The following is a description of a gene set: Human Gene Set: GOMF_TRANSFERASE_ACTIVITY_TRANSFERRING_ONE_CARBON_GROUPS studied in species Homo sapiens Catalysis of the transfer of a one-carbon group from one compound (donor) to another (acceptor)., and this is the list of marker genes: TMT1A, KMT5C, FDXACB1, FAM86B1, RRP8, METTL23, KMT2C, TRMT10C, METTL2B, PRDM6, KMT5A, NOP2, TRDMT1, METTL16, PEMT, EEF2KMT, TRMT11, TRMT13, THUMPD3, SUV39H1, PRDM1 (NCBI Gene Id 639), FTCD, PRDM12, FAM98B, MRM1, CAD, TRMT2B, EMG1, ASMTL, TRMT2A, TRMT61A, FBXO11, GNMT, PRDM8, TRMT5, ATPSCKMT, WDR5, NSUN6, COMT, TTLL12, PCMTD1, EZH2, NTMT1, NNMT, PRDM4, ATIC, VCPKMT, PRDM14, METTL2A, ETFBKMT, BHMT, METTL9, KMT2E, EEF1AKMT1, FAM86B2, HNMT, SETMAR (NCBI Gene Id 6419), SETD6, MRM2, SETDB1, HENMT1, PRMT8, TRMT10A, DOT1L, SMYD4, THUMPD2, SMYD1, GART, METTL3, METTL25B, NSUN4, PRDM11, PRMT2, TRMO, EEF1AKMT2, MRM3 (NCBI Gene Id 55178), CMTR1, CARM1, FAM86C1P, MTFMT, TRMT61B, METTL22, METTL15P1, SPOUT1, NSUN5P2, DNMT3A, DIMT1, NDUFAF5, METTL6, LCMT2, GAMT, AS3MT, MTR (NCBI Gene Id 4548), SIRT7, METTL1, SETD2, SETD1A, SMYD3, SETDB2, METTL13, TRMT1L, SETD9, SETD3, AMT, EZH1, METTL21EP, GATM, OTC, TFB1M, DNMT3B, FBLL1, BUD23, TARBP1, EHMT2, TYMS, ASMT, COQ5, NSUN7, PCMT1, FTSJ1, SUV39H2, TRMT10B, TGS1, EHMT1, SETD1B, CAMKMT, BCDIN3D, MECOM, ALKBH8, PRMT6, METTL21A, EEF1AKMT4, TRMT1, NTMT2, PRDM7, NSUN3, PRDM9, TRMT12, TFB2M, RNMT, JARID2, TRMT112, ZCCHC4, PRDM2, SETD5, ARMT1, SETD4, SETD7, SMYD5, LCMT1, NDUFAF7, NSUN2, SMYD2, FTSJ3, ECE2, PRDM10 (NCBI Gene Id 56980), PRDM15, METTL18, PRMT3, EEF1AKMT3, CMTR2, METTL15, NSUN5, PNMT, PCMTD2, WDR4, METTL24, TRMT44, SETBP1, METTL25, FAM86C2P, PRDM13 (NCBI Gene Id 59336), TYW3, PRMT5, METTL21C, METTL17, DNMT1, PRMT9, ANTKMT, COMTD1, EEF1AKMT4-ECE2, NSD3, METTL8 (methyltransferase 8, tRNA N3-cytidine), COQ3, HEMK1, PRMT7, FAM98A, NSUN5P1, TMT1B, PRDM5, NSD1, SAMTOR, FBL, CARNMT1, NSD2, METTL4, N6AMT1, TRMT9B, KMT2A, METTL5, KMT2D, MEPCE, PRDM16, CSKMT, PRMT1, ICMT, KMT5B, PCIF1, DPH5, METTL14, KMT2B, ASH1L, SHMT2, MGMT, INMT, SHMT1, BHMT2, TPMT